Given this list of marker genes P2RY6, PTAFR, P2RY4, P2RY11, GPR34, P2RY14, P2RY13, GPR171, P2RY2, GPR87, P2RY1, P2RY12, P2RY8, here is a description of the gene set: Combining with a purine nucleotide and transmitting the signal across the membrane by activating an associated G-protein; promotes the exchange of GDP for GTP on the alpha subunit of a heterotrimeric G-protein complex. studied in species Homo sapiens Human Gene Set: GOMF_G_PROTEIN_COUPLED_PURINERGIC_NUCLEOTIDE_RECEPTOR_ACTIVITY